The following is a description of a gene set: studied in species Mus musculus This event has been computationally inferred from an event that has been demonstrated in another species.<p>The inference is based on the homology mapping from PANTHER. Briefly, reactions for which all involved PhysicalEntities (in input, output and catalyst) have a mapped orthologue/paralogue (for complexes at least 75% of components must have a mapping) are inferred to the other species. Reactome Pathway: Regulation of T cell activation by CD28 family electronically inferred by orthology from the curated human pathway part of: Adaptive Immune System, and this is the list of marker genes: Psmb6, Psma6, Cd3d, Pik3cb, Pdpk1, H4c8, Sel1l, Psma4 (NCBI Gene Id 26441), H4c1, Psmb4 (proteasome (prosome, macropain) subunit, beta type 4), Spop, Ost4, H2ac19, H2bc13, Ppp2r5d, Psmd7, H4c3, Psma5, H2ac11, Pdcd1lg2, Map3k8, H2ac6, Prkag1, Psmd6, H4c2, H4c14, Map3k14 (NCBI Gene Id 53859), Pik3r5, H2bc8, H2bc9 (NCBI Gene Id 319182), Grap2, H2ac8, H4c17, Csk, Psma3, Tusc3, H2ac12, Ctla4, Psma7, Derl3, H2bc15, H2bc1, Ptpn6, Derl1, H3c10, H2bc3, H2ac7, H3c2, Cd28, Vav1, H3c8, H2bc22, Psmc3, Ezh2, H2ac23, H3c13, Cdk4, H4c9, Pak3, H2ac4, Psmc2, Cd274, Cul1, Csnk2b, Pik3r2, H2az2, H4c11, H2ac1, H2bc11, Psmc1, Pdcd1, Rbbp4, Prkag3, Yes1, Ccnd1, H2ac10, Stt3a, Cd3e, H2ax, Psmd13, Psmb5, Tmem258, H3c7, H2ac15, H4c4 (NCBI Gene Id 319156), B3gnt3, Mib2 (NCBI Gene Id 76580), Psma2, Psmc5, Rps27a, Psmc4, Stt3b, Cdc42, H2ac24, Ppp2r5b, H3c1, Them4, H3c15, H3c6, Erlec1, H4c18 (H4 clustered histone 18), Psmd1, Psmc6, Rbbp7, H3c3, Ubb, Fyn, Cd3g, Cd80, H4c12, Vcp, Icos, Ppp2r1b, H3c11, H2bc7 (H2B clustered histone 7), Ddost, H2ac20, H3f3a, Ppp2r5a, H2ac13, Psma1, Lck, Rictor, Dad1, Grb2, H4c6, H3c4, H2bc12, H2ac22, Tnfrsf14, H2bc27, Psmb7, Icosl, Psmd12